Given this list of marker genes NECTIN4, CKAP2L, SMARCE1, KCNH1, METTL27, NSD1, MAPK1, VEGFC, NOP10, SHANK3, GJB2, SLC35D1, GPC4, PRKACB, IL17RA, IL17RC, EIF4H, SMARCB1, BUD23, DLL4, PARN, TBX4, JUP, SMARCA2, COL17A1, GDF5, SMARCC2, TAF1, ARID2, LIMK1 (NCBI Gene Id 3984), DKC1, UBAP2L, PORCN, BMP2, EBF3, HRAS, DOCK6, TMEM270, FGFR1, IFT43, RAB3GAP2 (RAB3 GTPase activating non-catalytic protein subunit 2), BCR, WDR35, DST, PIEZO1, DPF2, WRAP53, WLS, CLEC7A, IFT52, ELN, ODC1, SHOC2, EDARADD, ERI1, RIPK4, GJC2, KIF1A, PPP2R5D, UMPS, RTEL1, KCNN3, APC, DYNC2LI1, RBPJ, IL17F, MSX1, TELO2, ARHGAP31, NOG, TYMS (NCBI Gene Id 7298), NECTIN1, ITGB4, LMNA, NOTCH1, COL7A1, IKBKG, TCTN3, KRT5, POLR1A, SOX4, PERP, AFF4, RAB3GAP1, PPP1CB (protein phosphatase 1 catalytic subunit beta), INPPL1, ZMPSTE24, TP63, RETREG1, WNK1, BHLHA9, WNT10A, RFC2, EVC, ATP6V1B2, DPH1, EIF5A, GLI1, LIG4, SMARCD1, CTC1, KLHL24, ZMYM2, BAZ1B, PLCD1 (phospholipase C delta 1), TINF2, NCF1, EZH2, LRP4, ARID1B, GTF2IRD2, NHP2, KDM1A, PEX1, COL11A1, EOGT (NCBI Gene Id 79580), USB1, PIGF, DNAJC30, SCO2 (NCBI Gene Id 9997), HOXA13, TBL2, FERMT1, TRAF3IP2 (TRAF3 interacting protein 2), TBX3, SOX11, CPT2, FLT4, IFT122, ZIC3, FKBP6, SET, RAB7A, NSUN2, EDAR, PRKACA, RUNX2, FTO, CRKL, KIF11, GTF2IRD1, ZSWIM6, EVC2, CLIP2, DSP (desmoplakin), VPS37D, GTF2I, DPH2, WDR19, SMARCA4 (SWI/SNF related, matrix associated, actin dependent regulator of chromatin, subfamily a, member 4), STX1A, TBC1D24, KRT74, SHOX, LMX1B, SCN9A, CSTB, SUZ12, PEX6, WNT7A, ANGPT2, KRT14, ARID1A, TERT, NPM1, TERC, here is a description of the gene set: studied in species Homo sapiens Human Gene Set: HP_ABNORMAL_TOENAIL_MORPHOLOGY An anomaly of the toenail. Abnormal toenail morphology